Given this list of marker genes KRT6A, RPGRIP1, AKT1, SOX5, GPC3, TMEM216, TMEM231 (transmembrane protein 231), TCTN2, SEC23B, B9D2, TMEM107, CEP290, IL36RN, MKS1, SREBF1, RPS6KA3, RAB3GAP1, TMEM67, HNRNPK, PTEN, KDM5C, GPC4, GJB2, KLLN, TMEM237, TCTN1, CSPP1, RERE, SDHC, ECEL1, RAB3GAP2, B9D1, SDHD, SDHB, CC2D2A, TCTN3, RPGRIP1L, PIK3CA, SLC39A4, INSR, TXNDC15, USF3, MED25, here is a description of the gene set: Accentuation of the grooves on the dorsal surface of the tongue. Furrowed tongue species: Homo sapiens Human Gene Set: HP_FURROWED_TONGUE